The following is a description of a gene set: The directed movement of a neurotransmitter receptor complex along microtubules in nerve cell dendrites towards the postsynapse. Mouse Gene Set: GOBP_ANTEROGRADE_DENDRITIC_TRANSPORT_OF_NEUROTRANSMITTER_RECEPTOR_COMPLEX species: Mus musculus, and this is the list of marker genes: Kifc2, Kif17, Kif3b, Kif5c, Kif3a, Kif5a, Kifap3, Kif5b